Given this list of marker genes USP8, NR3C1, PLOD1, F13A1 (coagulation factor XIII A chain), FBLN5, TP53, TNXB, NGF, USP48, ELN, ATL1, C1R, GJA1, DPP9, SEC61A1, F13B, AIP, CFH, ALK, COL1A1, NRAS (NCBI Gene Id 4893), CDH23, ADAMTS2, SCN11A, SPTLC1 (serine palmitoyltransferase long chain base subunit 1), HELLPAR, COL5A1, F8, ITGB2, CD46, DDR2, RAC2, SPTLC2, NTRK1, ARPC5, AEBP1, COL1A2, CEP104, BGN, ZEB2, COL5A2, DSE, ATL3, BRAF, SERPINE1 (serpin family E member 1), LMNA (NCBI Gene Id 7816), SOX5, ATRX, CFI, RAF1, COL12A1 (collagen type XII alpha 1 chain), GBA1, here is a description of the gene set: Human Gene Set: HP_POOR_WOUND_HEALING Poor wound healing species: Homo sapiens A reduced ability to heal cutaneous wounds.